The following is a description of a gene set: Human Gene Set: MIR4434 Genes predicted to be targets of miRBase v22 microRNA hsa-miR-4434 in miRDB v6.0 with MirTarget v4 prediction scores > 80 (high confidence targets). from publication Chen Y, Wang X (PMID 31504780) species: Homo sapiens, and this is the list of marker genes: TMEM178B, F9, BNC2, RTL4, CHPF, SP1, FBXW7, USP18, ALDH16A1, RNF10, BORCS7, SCAMP1, GYPE, RECQL5 (RecQ like helicase 5), SET, GPD1, MTCL2, ASCC1, PLAT, KLHDC8A, SLC7A6, PRR27, ASH1L, AASDH, DUOXA1, SEPTIN6, CCDC9B, CORO2B, ZKSCAN8, VAMP1, ABL2, FBXO46, NHSL3, FNBP4 (formin binding protein 4), SPATA33, KCND1, CPM, LRRC8B, FCGR1BP, FBXO21, ZMAT3, KIRREL1, RSPO4, MAN1A2, SVBP, TNFRSF21 (NCBI Gene Id 51323), NKAIN1, ERBB4, THUMPD2, OPCML, OTULIN, PIK3CB, SYNPO2L, DNMT3B (NCBI Gene Id 1789), ZNF22 (zinc finger protein 22), CEP250, FAAP20, ZKSCAN2, KMT2D, PLEKHG2, RHO, PAK1, TCF12 (transcription factor 12), CREB5, SIAH3, BTN2A1, CPLX4, TAS2R14, SLC26A10P, MSN, FMNL3, SAR1A, TOX3 (TOX high mobility group box family member 3), BTK, CDK6, SCGB2B2, FCHSD2, RASAL2, ZBTB2, PREPL, SRL, NFIC, PRP4K, FANCL, CEP85, EIF3J, SMG7, FSTL4, FN1, MAF, ITGA9, MS4A10, GPATCH2L, SPG7, FBN1, ANKS1A, NTRK2, SSBP2, DICER1, NECAP1, CDC20B, LINC03040, VPS29, GJB6, PPP3R1, FBXO32, AQP1, EXOSC3, TMCC2, SPCS3, ASB11, GIPC2, LYPD6, PLAGL2, FOXD2, DOCK3, ZNF133, AAK1, SCN3B, ST6GAL1, GNB4, KLHL42, ZDHHC7, ABHD16A, ADARB2, ZSCAN16, TXNRD1, LPXN, PALM2AKAP2, CILP2, PDE1C, TNRC6B, TTC22, MECP2, PABIR2, NHSL1, SASH1, PHF8, PAFAH2, FAM131B, IDH1, FAM135B, DDX6, ZC4H2, GAS7, FBXO28, ARHGEF4, AHCYL2, CCBE1, GALP, NT5C1B-RDH14, MTMR7, CD276, R3HDM2 (NCBI Gene Id 51220), ANKFY1, ZFP3, DSCAML1, EBF1, SLC25A21 (NCBI Gene Id 89874), ELOVL5, KLHL13, EGR3, TRPM7, CDH7, SHF, AKAP13, ELF2, ING4, CLTCL1, TMEM214, LRP4, SNTB2